Given this list of marker genes Kdelr3, Cog8, Tubb6, Kdelr2 (KDEL (Lys-Asp-Glu-Leu) endoplasmic reticulum protein retention receptor 2), Arf1, Arf5, Dync1li2, Gorasp1, Sptbn4, Copb2, Cog7, Actr10, Actr1a, Copg2, Dynll1, Tubal3, Tuba1c, Rab1a, Tubb2b, Ank1, Cd55, Tuba3b, Uso1, Dctn1, Ins1, Tuba1a, Tuba4a, Copg1, Arcn1, Folr1, Tmed10, Arfgap2, Copb1, Dctn6, Ins2, Bet1, Tubb4b, Sptbn2, Rab1b, Nsf (NCBI Gene Id 18195), Tubb4a, Tmed3, Kdelr1, Tuba1b, Tmed9, Tuba8, Golga2, here is a description of the gene set: This event has been computationally inferred from an event that has been demonstrated in another species.<p>The inference is based on the homology mapping from PANTHER. Briefly, reactions for which all involved PhysicalEntities (in input, output and catalyst) have a mapped orthologue/paralogue (for complexes at least 75% of components must have a mapping) are inferred to the other species. species: Mus musculus Reactome Pathway: COPI-mediated anterograde transport electronically inferred by orthology from the curated human pathway part of: ER to Golgi Anterograde Transport